The following is a description of a gene set: Kaposi's sarcoma (KS) is the most frequent AIDS-associated malignancy, etiologically linked to the infection with the human herpesvirus 8 (HHV-8/KSHV). This member of the gamma-herpesviridae family encodes 81 open reading frames, several bearing oncogenic potential. A constitutively active virally encoded G protein-coupled receptor (vGPCR) readily induces KS-like lesions when expressed in endothelial cells in vivo, and unmasks the oncogenic potential of other HHV-genes in a paracrine fashion. How vGPCR causes endothelial cell transformation is still not fully understood. Using full-genome microarray analysis we show here that the expression of nuclear factor-kappaB (NF-kappaB)-regulated genes is a prominent feature triggered by vGPCR in cells expressing this viral oncogene and in cells exposed to vGPCR-induced secretions, thus mimicking its paracrine effect. Indeed, vGPCR activates the NF-kappaB pathway potently, and NF-kappaB activation is a hallmark of both human and experimental KS. Of interest, whereas constitutive NF-kappaB signaling is not sufficient to promote endothelial cells transformation, NF-kappaB function is strictly required for vGPCR-induced direct and paracrine neoplasia. Taken together, these results strongly support the role of NF-kappaB regulated genes in KS pathogenesis, thus providing the rationale for the development of novel mechanism-based therapies for this angioproliferative disease. studied in species Mus musculus NF-kB-controlled genes down-regulated in endothelial cells in response to viral GPCR protein. Human Gene Set: MARTIN_NFKB_TARGETS_DN from publication Martin D, Galisteo R, Ji Y, Montaner S, Gutkind JS (PMID 17934524), and this is the list of marker genes: SLC14A2, DHCR24, ZCWPW2, EFNB3, BRD1, DGKQ, BRSK1, DNASE2, COLGALT2, UBN1, MEAK7